The following is a description of a gene set: Human Gene Set: SOX11_TARGET_GENES Genes containing one or more binding sites for (SOX11) in their promoter regions (TSS -1000,+100 bp) as identified by GTRD version 20.06 ChIP-seq harmonization. species: Homo sapiens from publication Yevshin I, Sharipov R, Kolmykov S, Kondrakhin Y, Kolpakov F (PMID 30445619), and this is the list of marker genes: CFL1, RPL23, MALAT1, THOC5, GTF2IRD1, SLC29A3, SNRPA, MYOSLID-AS1, OSGEP, MIRLET7I, RNF44, ZNF565, ANAPC15, ZNF3, RANBP1, RBMX, ZNF43, ZNF397, HMGB1, LINC02453 (long intergenic non-protein coding RNA 2453), PBRM1, CUEDC1, MCM7, AP4M1, MTF2, TTF1, ACTMAP, TRMT2A, ZNF140, GNL3, COX20, LINC01465, CHD2, HLA-A, CEP41 (centrosomal protein 41), ZNF747, KDM2A, EPC1-AS1, PLEKHG4B, ZNF146, ZNF747-DT, CAPRIN1, XIST, APEX1, SFPQ, EPC1-AS2, SETMAR (SET domain and mariner transposase fusion gene)